Given this list of marker genes CD33, DUSP1, FES, RNF130, LILRB2, FGL2, PPT1, NOD2, CASP1, TLR8, MS4A6A, CLEC4A, TLR2, IER2, TBXAS1 (thromboxane A synthase 1), VNN1, CFP, NAIP, SLC7A7, MAFB (MAF bZIP transcription factor B), TNFAIP2, RGS2, DUSP6, VCAN, FCN1, CD14, NLRP3, CYBB, CD163, FOS, BST1, PYCARD, TYROBP, CD302, CD1D, ADA2, CPPED1, LILRB3, CTSS, CD93, MFSD1, FCGR1A (Fc gamma receptor Ia), STX11, LILRA3, CPVL, LILRA1, PLBD1 (phospholipase B domain containing 1), HK3, LILRA6 (leukocyte immunoglobulin like receptor A6), IFI30, AP1S2, LGALS2, here is a description of the gene set: Human Gene Set: GNF2_CD33 studied in species Homo sapiens Neighborhood of CD33 CD33 molecule in the GNF2 expression compendium Neighborhood of CD33